Given this list of marker genes MECOM, HOXA11, BRAF, PTPN11, MPL (NCBI Gene Id 4352), MAP2K1, here is a description of the gene set: Human Gene Set: HP_AMEGAKARYOCYTIC_THROMBOCYTOPENIA Amegakaryocytic thrombocytopenia Thrombocytopenia related to lack of or severe reduction in the count of megakaryocytes. studied in species Homo sapiens